The following is a description of a gene set: from publication Chen Y, Wang X (PMID 31504780) Genes predicted to be targets of miRBase v22 microRNA mmu_miR_7081_5p in miRDB v6.0 with MirTarget v4 prediction scores > 80 (high confidence targets). Mouse Gene Set: MIR_7081_5P studied in species Mus musculus, and this is the list of marker genes: Camk1, Sec22c, Cplx1, Ric8a, Nuggc, Arrdc1, Kmt2a, C5ar1, Gdpd4 (glycerophosphodiester phosphodiesterase domain containing 4), Mllt1, Ncln, Dlgap4, Katnbl1, Fgd1, Sypl2, Zfp346, Twist2, Tnfsf8, Evi2b, Rgs11, B4galt3, Srf, Lrrc71, Parvb, Atp6v0c, Myoz3, Hip1, Rab6a, Rgs8, Gcn1, Ttc39d, Ilrun, Nav1, Fbxw8, Slc35d1, Psmd11, Arf3, Srrm4, Olr1, Zfp710, Cpa4, Svopl, Ciapin1, Slc44a5, Wnt1, Susd6, Zfyve28, Chst14, Ccser2, Rdh16, Ar, Pgm3, G6pdx (glucose-6-phosphate dehydrogenase X-linked), Tkfc, Lin7a, Phospho1, Baz2a, E2f2, Dpysl3, Ywhaz, Mtcl2, Nhsl3, Mtss2, Lasp1, Dmrta1, Odad1, Ccbe1, Il2ra, Ppp1r1c, Lrrc63, Synpo2l, Prg4, Mbd4, Fndc3a, Snhg11, Ihh, Pum1, Mlph, Man1b1, Diras1, Ipcef1, Gmfb, Klk4, Tat, Rinl, Card10, Nras, Exph5, Pea15a, Gdi1, Foxj2, Slc8a1, Mrgpre, Lbh, Trp63, Pkp2, Arsk, Dtx4, Map3k9, Rps6ka1, Tgm2, Brpf3, Nhsl2, Gca, Taok1, Itsn1, Jph4, Mpp2, Gal3st3, Tifab, Man1a, Lrrc8d, Abcg4, Bcl11b, Eppk1, Kank2, Gnal, Mgat4c, Nxf1, Igsf9b, Sbk3, Runx1t1, Nkx2-1, Yeats4, Braf, Klf8, 6430548M08Rik, Dpysl5, Nol4l, Arcn1, C1ql2, Lingo1, Fam76a, Gpatch8, Amer2, Prom2, Khdrbs2, Siglecl2, Vapb, Tbc1d5, Xpnpep1, Col4a4, Pitpnb, Usp46, Cdk17, Stk32b, Lilrb4a, Trim67, Nkain2, Dscaml1, Slc24a3, Mfrp (NCBI Gene Id 259172), Kirrel1, Sec14l1, Pxk, Cbl, Cyp17a1, Nlrp3, Mylk4, Glg1, Pomk, Srgap3, Wasf2, St6galnac3, Minar2, Sema4g, Strc (NCBI Gene Id 269343), Krtap5-4